The following is a description of a gene set: studied in species Homo sapiens Any process that activates or increases the frequency, rate or extent of membrane protein ectodomain peptidolysis. Human Gene Set: GOBP_POSITIVE_REGULATION_OF_MEMBRANE_PROTEIN_ECTODOMAIN_PROTEOLYSIS, and this is the list of marker genes: RGMA, SNX9, APP, ADAM9, SH3D19, SNX33, FURIN, TNFRSF1B, IL1B, IFNG, PACSIN3, ADRA2A, ADAM8, APOE, GPLD1, TNF, NRDC